Given this list of marker genes FRS2, NTF4, NTRK2, SRC, RAC1, TIAM1, PLCG1, GRB2, PIK3R1, NRAS, GRIN2B, FYN (FYN proto-oncogene, Src family tyrosine kinase), SOS1, PIK3CA, CDK5, SHC1, KRAS, CDK5R1, GAB1, BDNF, FRS3, NTF3, HRAS, PTPN11, DOCK3, here is a description of the gene set: Reactome Pathway: Signaling by NTRK2 (TRKB) NTRK2 (TRKB) belongs to the family of neurotrophin tyrosine kinase receptors, also known as NTRKs or TRKs. Besides NTRK2, the family includes NTRK1 (TRKA) and NTRK3 (TRKC). Similar to other receptor tyrosine kinases (RTKs), NTRK2 is activated by ligand binding to its extracellular domain. Ligand binding induces receptor dimerization, followed by trans-autophosphorylation of dimerized receptors on conserved tyrosine residues in the cytoplasmic region. Phosphorylated tyrosines in the intracellular domain of the receptor serve as docking sites for adapter proteins, triggering downstream signaling cascaded. Brain-derived neurotrophic factor (BDNF) and neurotrophin-4 (NTF4, also known as NT-4) are two high affinity ligands for NTRK2. Neurotrophin-3 (NTF3, also known as NT-3), a high affinity ligand for NTRK3, binds to NTRK2 with low affinity and it is not clear if it the low level of activation of NTRK2 by NTF3 plays a physiologically relevant role. Nerve growth factor (NGF), a high affinity ligand for NTRK1, does not interact with NTRK2. NTRK2 activation triggers downstream RAS, PI3K, and PLCgamma signaling cascades, thought to be involved in neuronal development in both the peripheral (PNS) and central nervous system (CNS). In addition, NTRK2 plays an important, but poorly elucidated, role in long-term potentiation (LTP) and learning. NTRK2 may modify neuronal excitability and synaptic transmission by directly phosphorylating voltage gated channels.<p><p>It was recently demonstrated that the protein tyrosine phosphatase PTPN12 negatively regulates NTRK2 signaling and neurite outgrowth. In the presence of PTPN12, NTRK2 phosphorylation at tyrosine Y816 decreases. It has not yet been demonstrated that PTPN12 acts directly to dephosphorylate Y816 (and possibly other phosphotyrosines) of NTRK2.<p><p>Binding of SH2D1A (SAP) to NTRK2 attenuates NTRK2 trans autophosphorylation and downstream signaling through an unknown mechanism.<p><p>Little is known about downregulation of NTRK2 (TRKB) receptor via ubiquitin dependent pathways (Sanchez Sanchez and Arevalo 2017). CBL, a ubiquitin ligase involved in degradation of many receptor tyrosine kinases, was shown to ubiquitinate and, unexpectedly, increase stability of NTRK2. NTRK2 undergoes ubiquitination by the TRAF6 E3 ubiquitin ligase complex. While ubiquitination by the TRAF6 complex negatively regulates NTRK2 induced AKT activation, the effect of TRAF6 mediated ubiquitination on NTRK2 protein levels has not been examined.<p><p>Downregulation of the TRKB receptor may depend on the activating ligand, with BDNF inducing more rapid ubiquitination and degradation compared to NTF4 (NT 4). NTRK2 undergoes both lysosome dependent and proteasome dependent degradation upon stimulation by BDNF, while stimulation by NTF4 may protect NTRK2 from the lysosome degradation route. studied in species Homo sapiens part of: Signaling by NTRKs